Given this list of marker genes NEAT1, RAB28, OPN3, CYFIP2, TOR1A, RPL26L1, ZC3H14, TRPS1, ZNF135 (NCBI Gene Id 7694), FAF1, TTF1, SEC22B, SCAF11, PPP2R5E, GNAQ, RBM41 (RNA binding motif protein 41), ACLY, API5, TUBB3, ADRB2, EIF3M, HNRNPD, KPNA1, CNTRL, CAPZA1 (capping actin protein of muscle Z-line subunit alpha 1), ATF2, LIMK2, TRIM44, ABHD18, ORC3, HDAC1, PLXNC1, LGALS9, CENPU, GALNT1, TBL2, EEA1, SLC38A2, SENP3, LPCAT3, EIF2B1, PPP1R12A, EIF5, COG2, EMC2, ATG12, GTF2H5, BMPR2, DDX27, TRIM38, HGSNAT, SAP30BP, RBM28, MDFIC, LSM12 (LSM12 homolog), WBP4, KPNB1, BCL11A, RBM10, OSTF1, MAP3K7, RNF130, FAR2 (fatty acyl-CoA reductase 2), GGPS1, MEF2A, APAF1, COX16, RAB8A, DERL2, IL4R, NPM1, AP2B1, ZFR, SRSF7, TERF2IP, PSMA2, TNFSF13, COX7A2, ENTREP3, OXCT1, PHKB, TNPO2, RPL7, TAOK3 (TAO kinase 3), EIF3A, KMT5B, FKRP, NCK1, TNIP1, PAFAH2, DNAJB14, ARHGAP26, RBMS1, BPTF, EIF2S1, JPT2 (NCBI Gene Id 90861), HSPH1, KLHDC2, SAGE1, RIOX2, DCK, KMO, SMAD2, FXYD5, GNAS, LRRC8D, GBA1LP, CIITA, RBM15B, SP4, LIN37, TPR, KYAT3, POLR2H, HIRIP3, BUD31, GPHN, APOBR, UBE4A, DDX3X, TRPV2, MFN1, MPG, TOR1B, NUBP1, KLF12, UBR7, SIDT1, PHF21A, MYEF2, PAFAH1B1, DESI1, TAF12, COPA, NOL7 (nucleolar protein 7), SERINC3, SENP6, MALT1, PLA2G2D, PTK7 (NCBI Gene Id 5754), TASOR, HARS1, RNF8, WASHC4, NFYC, ROGDI (NCBI Gene Id 79641), MRPS16, FBXO22 (NCBI Gene Id 80234), STRAP, HTR2A, UBE2K, PASK (PAS domain containing serine/threonine kinase), SLC5A6, GSPT1, HEBP2, RFWD3, CYBB, SELENOT, SMG7, RTCB, BMP2K, ATRX, TMEM185B, FNBP4 (NCBI Gene Id 23360), PPP1R7, RAB6B, ARMCX3, BBIP1, RPS15, PTPN22, INHBC, TIMM9, APEX2, ABCA6, KLF6, LTN1 (NCBI Gene Id 89753), DHX40, RPS6, SYK, TMCO6, PSMG1, SART1, AIP, ZMYND8, RCAN3, EAF2, RGS7, KLHL28, CRLF3, RBBP6, SSB, ZNF629, SRRD, BRD4, MAT2A, YIPF6, MBNL2, PIP4K2A, DERA, RNF40, here is a description of the gene set: studied in species Homo sapiens Genes down-regulated in comparison of plasmacytoid dendritic cells (pDC) from influenza vaccinee pre-vaccination versus those at day 7 post-vaccination. from publication Nakaya HI, Wrammert J, Lee EK, Racioppi L, Marie-Kunze S, Haining WN, Means AR, Kasturi SP, Khan N, Li GM, McCausland M, Kanchan V, Kokko KE, Li S, Elbein R, Mehta AK, Aderem A, Subbarao K, Ahmed R, Pulendran B (PMID 21743478) Human Gene Set: GSE29618_PRE_VS_DAY7_FLU_VACCINE_PDC_DN Systems vaccinology has emerged as an interdisciplinary field that combines systems wide measurements and network and predictive modeling applied to vaccinology. Here we used the systems vaccinology approach to study the molecular mechanisms underlying th